Given this list of marker genes USP46, TRIP11, TRIM33, PCDH20, ANKRD33B, EP300 (NCBI Gene Id 2033), AP3D1, TES, CHRM2, CCND1, ZNF850, CDIN1, MAP3K2, PHLPP2, RASD1, NDNF, NBR1, RNASE9, PPM1A, CMBL, MPDZ, ITGB8, ADAM22, CCSAP, PDGFC, ADGRL3, FSD1L, IFRD2, AMELX, MED12L (mediator complex subunit 12L), SETD2, BCL2L11, MAGEB6, UTP23, LRP12, UGCG, REST, F3, PKD2, ANO6, BRWD3, CKAP2, LRFN5, TMEM68, L3MBTL1, DPP10, SLC31A2, ENTPD7, MCF2L2, PHTF2, PDLIM5, MAGOHB, RXFP1, YY1, PPP1R15B (protein phosphatase 1 regulatory subunit 15B), PDK4, CITED2, SMARCA5, CYB561D1, MTF1, TXNIP, FZD1, DDHD1, FZD4, DPP8, UNC5D, RRAGD, DCDC2, FAM76B, FAM120A, FOXJ3, MAGI3, RBSN, NEFH, AAK1, MMP13, RPS6KA4, FBXL5, PRICKLE2, HIBCH, GIPC2, NSD2, NPAT, KIF23, SCAND3, ETV1, HIVEP3, GRM5, FLRT3, PLCH1, MAN1A2, FUNDC2, RNF128, WDCP, BCAT1, EGLN3, EXOSC5, COBL, KCNAB1, MS4A14, PTDSS1, EPAS1, LRRK1, STIM2, RASGRF2, ZNFX1, TNRC6B, FRMD6, SH3PXD2A, FGD5, TNFRSF21, IKZF2, CXCL5, FBXL3, TOX, NRIP1, PCDHA1, LEPROT, LAMA3, UBASH3B, FNBP4, TRIM36, ERG28, ATG16L1, BTF3L4, VASH2, CD36, SPOCK1, CSRNP3, MTMR10, COIL, NRG3, GRIP1, NASP, ARHGAP26, SPSB4, COX7A2 (NCBI Gene Id 1347), MIER1, AQP4, CLOCK, TRPC1, SHTN1 (shootin 1), PRKCH, VANGL1, KGD4, C3orf70, ANO5, RBM12B (NCBI Gene Id 389677), DNAJC27, DENND5B, SLC24A2, FAM168A, SLAIN2, KRT10, SCAI, EML1, TNFSF13B, MFAP3L, EGR3, KLHL2, RAPH1, MYLIP, SPAG9, VASP, SERTM1, REV3L, ZNF514, ADD1, FRS2, GMDS, SGMS2, SEPTIN8, ACER3, LAMP3, CLEC12A, GKAP1, BMP2K, LITAF, MED17, FZD3, MATN3, FUBP1, BTG2, SLC16A7, PPP3CA, PRKD3, PHIP, PLPPR5, KMT5B, GPN3, BZW1, RYK, STRN, DOCK4, ASTN2, AVIL, KRTAP4-7, OSBPL8, POU2F1, TRIM13, AKR7A2, NDUFA5, MRPS25, LYPLA1, GNAI1, PRKAR2B, TYRP1, RRAS2, TMEM255A, ELK3, PDE5A, IL6ST, ST8SIA3, RNF38, CD5L, MYT1L, ACTR2, MARK3, HNRNPL, ITGA4, GPC4, MASTL, MKRN1, YWHAB, ZFYVE21, FURIN, NT5E, FAM117B, PBLD, KLHL15, PLPPR1, DUSP2, TBC1D8, PDE7B (phosphodiesterase 7B), DOCK7, ADAMTS5, ZFHX4, AKAP11, PTPN4, SLC39A8, BTG3 (NCBI Gene Id 10950), DNAJC15, ZFYVE26, OSMR, GUCY1A2 (NCBI Gene Id 2977), ACOX3, CEP97, NENF, SDC2, TMEM9B, RAD21, PIK3C2A, EPHA4, PLEKHA3, RCOR1, SSH2, RUNX1, B3GALNT2, E2F5, ZDHHC21, OTUD4, XIAP, AGFG1, ZBTB20, TMEM128, ZNF800, AHI1 (Abelson helper integration site 1), TNC, BTG1, ADAM10, ENPP5, NFAT5, DCTN6, EIF4A2, SLC36A1, BRMS1L, RAP2C, LMO3, NTRK3, YOD1, TDRD6, SLCO4C1 (NCBI Gene Id 55385), RARB, TMEM245, SCD, NEUROD1, PPARD, C2CD2, STRIP2, RAMAC, HSPA8, PRR15, CDC25A, SCN1A, PPP2R3A, MARCHF6, TMEM168, ZFYVE9, SACS, ITGB1, GOLPH3, TMCC3 (transmembrane and coiled-coil domain family 3), GPR137B, ARMC8, MAP3K20, FEM1C, KCNB1, SMG1, MED13, NRIP3, YWHAQ, NEDD4, GXYLT1, CNTLN, NBEAL1, JPT1, RPS6KA5, KDM3B, TOX3, C12orf75, TBC1D20, HMGB2, CEP44, IL12A, HERC1, TRIP10, IFI44L, USF3, BICC1, CNGB3, PEX5L, RBMX, RAB8B, SMIM13, KCNK10, GPR6, PPP1R1A, AMPD3, SLCO1C1, SLC35A5, NIBAN2, INIP, MAPRE3, CETN2, STMN1, TBC1D9, RASL11B, EZH1, UBE2D1, KCNE4, here is a description of the gene set: species: Homo sapiens Human Gene Set: MIR548AH_5P from publication Chen Y, Wang X (PMID 31504780) Genes predicted to be targets of miRBase v22 microRNA hsa-miR-548ah-5p in miRDB v6.0 with MirTarget v4 prediction scores > 80 (high confidence targets).